Given this list of marker genes HLA-DQA1, SLC46A1, OTUD5, ZNF699, HLA-DQB1, here is a description of the gene set: Reduced blood folate concentration Human Gene Set: HP_REDUCED_BLOOD_FOLATE_CONCENTRATION studied in species Homo sapiens A reduced circulating concentration of folic acid, which is also known as vitamin B9.